The following is a description of a gene set: Enables the transfer of an ion from one side of a membrane to the other. Human Gene Set: GOMF_MONOATOMIC_ION_TRANSMEMBRANE_TRANSPORTER_ACTIVITY species: Homo sapiens, and this is the list of marker genes: KCNK17 (NCBI Gene Id 90081), SLC30A10, KCNJ18, TRPC3, ATP5ME, SLC18A3, SLC30A9, MT-ND6, TRPM7, CACNA1G, SFXN2, CACNB2, KCNQ1, TPCN1, MT-CO1, CATSPER2, PCSK9, HCN1, MT-CYB, KCNG3, NMUR2, GABRG2, ATP1B1, SLC39A9, SCN2B, SLC39A5, DRD4, TSPOAP1, SLC38A3, ATP2B4, CACNA2D2, SLC2A9, NIPAL4, SLC18A1, SLC45A2, CACNA1H, SLC1A3, SLC39A4 (NCBI Gene Id 55630), KCNQ4, CHRNA2, ATP6V0A1, KCNK13, CALHM5, HTR3B, PIEZO2, TMPRSS3, STOM, SLC26A4, HCN2, GLRA3, CLCN1, TMC5, SLC26A7, CABP4, SLC9C1, SLC6A18, CRISP1, SLC39A10, CLDN4, NDUFS1, SLC23A1, ANO6, CACNA1A, SLC5A7, SLC28A1 (NCBI Gene Id 9154), KCNK3, KCNG4, TCIRG1 (NCBI Gene Id 8845), SLC34A2, ASIC5, ATP6V0C, FLNA, STIMATE, SLC24A3, SGK3, GPD1L, NDUFS3, ORAI2 (NCBI Gene Id 84917), NDUFS2, CLCN7, ASIC2, ATP6V1B1, GPR89A, KCNH5, AGT, KCNJ12, SLC17A8 (NCBI Gene Id 64944), PKD1L1, GABRE, GJD3, PKD2, SLC9A2, GABRR1, OCA2, CYC1, PKDREJ, GRIK4, ANK3, KCNH2, FXYD5, SLC9A6, NIPAL2 (NIPA like domain containing 2), CHRNA4, SLC11A1, NDUFS8, TMCO3 (transmembrane and coiled-coil domains 3), SLC38A1, TRPM2, KCNK16, CACNA1C, UQCR10, TRPC6, SCN9A, SLC38A7, ATP13A2, RSC1A1, ATP2C1, SLC25A4, KCNK6, KCNA10, NDUFB10, ANO10, GRIN1, CACNA1F, NEDD4, NDUFS6, ATP6V1G1, ANK2, NDUFV3, AQP1, GRIK1, TRPC7, SLC26A11, NDUFC2, TRPV1, SLC28A3, ATP6V1E2, GABRA4, SLC30A8, SLC46A1, SLC5A9, SLC17A7, CNGB1, SLC31A1, SLC26A5, SLC39A6 (solute carrier family 39 member 6), VTI1B, MT-CO3, DPP6, ANKRD36C, LAMP2, RYR1, HAMP, MT-ATP6, STX8, TTYH2, SLC12A2, TMC4, NIPAL1, NDUFS5, CACNG1, REM1, SLC5A4, SLC16A1, SEC61A1, SLC10A2 (NCBI Gene Id 6555), ENSA, NDUFB2, SCN10A, SLC9A8, VAMP8, SLC10A1, APOL1, NHERF1, SLC8A2, ANO3, CACNA2D1 (NCBI Gene Id 781), STIM1, SLC25A14, SLC1A2, NDUFB4, SLC39A7, LAMP1, UCP1, CACNA1S, CHRNA1, KCNV1, TMEM109, COX5B, KCNMB4 (NCBI Gene Id 27345), GABRQ, NDUFB6, MT-CO2, CLIC4, TMEM37, COX4I1, PDE4D, ATP4A, CLCA1, PACSIN3, SLC26A3, SLC13A3, KCNH1, SLC12A7, GABRA6, KCNJ16, UQCRH, SLC18B1, SLC25A22, CALHM4, TTYH1, CLIC2, CHRFAM7A, FKBP1A, CACNG4, GRIN2D, KCNJ8, COX6B1, SCN2A, SLC17A4, SLC30A6, BEST4, ATP5PF, SLC39A3, SLC8B1, ANO2, SLC46A3, SLC5A12, SLC15A1, ZACN, SCN3A, TMC6, ATP13A3, HCN4, ATP2A2, PHPT1, NDUFA7, SLC10A4, SLC25A28, KCNH8, P2RX7, SLC5A11, P2RX6, GRIK5, SLC4A8, SLC5A2, SLC25A12, ASIC1, SLC13A1, KCNMA1, NNT, CUL5, CNGA4, CABP5 (calcium binding protein 5), TMEM120A, KCNK9, SLC30A2, PSEN1, GABRA5, NOX5, FKBP1B, TMC2, SLC15A2, ROMO1, MFSD2A, NDUFA1, KCNN2, KCND2, TUSC3, BEST3, SLC1A6, ATP6V1F, KCNG2, ITPR1, KCNN4, SLC47A2, P2RX3, SLC10A3, ANO1, CATSPER3, SLC9A7, ATP4B, CAV3, TRPM6, GABRR3, ATP6V0E1, ASIC3, CACNB1, COMMD1, KCNJ3, NDUFB1, HCN3, GLRA1, SLC36A1, PKD1, SLC4A11, SGK2 (NCBI Gene Id 51178), REM2, SLC17A3, SLC5A10, GRID2, STX7, COX7A1, ATP8A1, KCNE5, TMC8, KCNAB1, CCT8L2 (chaperonin containing TCP1 subunit 8 like 2), ATP5F1A, GJA1, NDUFB9, TMEM38B, NDUFA12, PKD2L1, GJC1, ATP5MF, ADRB2, MT-ND4, ATP11B, NDUFC1, NDUFA6, TMCO1, KCNK12 (potassium two pore domain channel subfamily K member 12), SLC39A13, SLC39A12, SLC30A5, KCNC3, SLC17A2, SLC6A20, VDAC3, ATP6V0E2, SCN11A, ATP1A3, SLC6A14, KCNMB3, GPR89B, SLC39A11, CTNS, SCN1A, CACNG3, GRIN3B, ORAI1 (ORAI calcium release-activated calcium modulator 1), LRRC55, CLCN2, SLC39A2, TRPM1, CLCN3, OTOP2, ANO5, CLCN5, SCN3B, SLC28A2, SLC25A3, SLC12A9, MT-ND3, KCNB2, KCNQ2, PIEZO1, ATP5MC3, TPTE, AMIGO1, SLC26A1, ATP6V1G2, PTPN3, AKT1, SCN4B, CNGA1, KCNK18, SLC22A1, TRPC4AP, LETM1, GRIA1, FXYD6P3, KCNJ11, TMEM94, SLC13A4, CHRNB3, SLC11A2, CALM3, TMEM165, CNNM4, SLC29A1, CACNG8, FGF11, MAGT1, KCNN3, P2RX2, CACNA1I, KCNH6, SLC19A1, SLC9A9, NDUFB7, KCNA1, KCNU1, KCNJ2 (potassium inwardly rectifying channel subfamily J member 2), BSND, NCS1, STIM2, SLC6A8, SLC12A5, FXYD7, KCND3, CLIC1, GLRX, SLC13A2, SLC26A2, SLC45A4, ORAI3, SCN5A, CLCNKA, TRPV5, UQCRFS1, SLC24A1, PANX3, KCNJ9 (NCBI Gene Id 7820), SLC2A13 (NCBI Gene Id 114134), GHITM, KCNF1, SFXN5, CLCN4, ATP7A, HTR3D, CACNG2, GABRA2, NDUFA8, RYR3, RANGRF, NRXN2, CALM1, DRD2 (NCBI Gene Id 91906), CHRNA10, KCNC1, SLC6A7, SLC2A10, FGF12, CACNB4, SLC30A4, KCNAB3, CALHM1, SLC17A5, SLC8A3, TMEM168, CHRNA3, SLC26A8, CHRNB1, NDUFV2, GEM, KCNE3, ATP12A, KCNA5, RASA3, SLC17A6, ATP13A1, AQP6, SCN4A, KCNH4, LRRC8C, CACNG7, ABCC8, S100A6, KCNH7, MTCO2P12, DLG1, MCOLN1, SGK1, NDUFB5, ATP2B2, KCNQ5, KCNK15, GABRB3, CHRNA6, UQCRFS1P1, SLC26A9, COX8A, CACHD1, SLC9B2 (NCBI Gene Id 133308), GRIN2A, GABRA3, TMEM120B, UCP3, CALHM6, SLC45A3, UCP2, ATP2C2, LRRC26, BEST2, TMC1, MT-ATP8, KCNC2 (potassium voltage-gated channel subfamily C member 2), PKD1L2, GRM2, PACC1, KCNIP4, KCNA3, SFXN3, NDUFS4, SNTA1, OPRM1, SLC9A1, GABRB2, CATSPER1, SLC25A13, ASIC4, FXYD1, TRPV4, SLC20A2, SLC24A2, CHRNA5, NPY2R, GABRP, SLC30A1, SLC32A1 (solute carrier family 32 member 1), VDAC1, CALM2, CHRNA9, CALHM2, SNAP25, ATP6V1C1, ATP6V1H, UQCRC1, HVCN1, CACNA1B, CABP1, ATP6V1A, GPLD1, KCNG1 (potassium voltage-gated channel modifier subfamily G member 1), RRAD, GRINA, CACNA1E, SFXN1, MT-ND4L, ATP6V1G3, LYNX1, ATP5F1EP2, CLCA4, KCNJ10, SLC5A6, MFSD8, RYR2, GRIK3, WWP2, SLC5A5, FGF13, FHL1, KCNE1, SLC12A8, TNNI3, SLC30A3, ATP6V0D2, SCN7A, KCNJ14, CHRNB2, CNNM2, NEDD4L, CNGA3, GRIN2B, GABRD, CLIC5, SLC18A2, NDUFA9, ATP6V1B2 (ATPase H+ transporting V1 subunit B2), GABRR2, FXYD2, CACNA2D4, LRRC52, CLCA2, C8orf44-SGK3, SLC4A4, SLC17A1, SLC47A1, SLC25A18, CACNA2D3, YWHAH, KCNMB1, KCNAB2, TPCN2, P2RX4, KCNMB2, ATP5MGL, LRRC38, SRI, KCNIP2, KCNE2, ABCC9, SLC15A3, PLP2, TPTE2, GRIK2, COX7A2L, KCNT1, SLC24A4, ATP5PD, SFXN4, TRPA1, CLIC3, ATP5MC2 (ATP synthase membrane subunit c locus 2), SLC6A3, SLC39A14, KCNJ1, MT-ND1, TRPM5, ATP2A3, ZDHHC13, SLC15A4, STK39 (NCBI Gene Id 27347), CACNG5, LASP1, SLC12A1, ATP6V0B, ATP6V1E1, TRPV3, ATP13A4, SHOC2, GABRG1, SLC6A12, HTR3E, CNGB3, SUMO1, ATP5F1D, KCNN1 (potassium calcium-activated channel subfamily N member 1), MT-ND5, TRPC1, ITPR3, VDAC2, SLC6A1, NIPA2, SLC6A15, RACK1, SLC1A4, SLC12A4, SLC39A8, CLCC1, HTR3C, ATP2B1, KCNT2, CNGA2, ATP5F1B, MCOLN3, SLC4A1, NPY, SLC6A4, SLC4A10, MMGT1, SLC16A3, SLC41A2, SLC36A3, HPCAL4, TMEM175, FGF14, ANO9, ATP5F1E, GRM3, ARPP19, FXYD3, KCNK1, GABRA1, SLC26A6, ANXA6 (NCBI Gene Id 309), ANO7, STING1, TMEM150C (transmembrane protein 150C), NDUFS7, KCNB1, GRIA3, SLC6A6, HTR3A, CAMK2D, SLC4A7, SLC45A1, SLC5A3, BNIP1 (NCBI Gene Id 662), GRIA2, SLC5A8, CHRNB4, ATP6V0A2, KCNIP3, TRPV6 (NCBI Gene Id 55503), TMC3, LRRC8D, SLC24A5, KCNJ6, LRRC8A, YWHAE, TMBIM1, NDUFA2, NALCN, CLDN17, LRRC8B, ATP5PB, TMBIM4, SLC38A5, KCNK10, KCNS2, NDUFA3, KCNJ5, SLC13A5, PKP2, CHRNG, TMEM87A, UNC80, GLRA2, NIPA1, SLC1A7 (solute carrier family 1 member 7), SCNN1B, ATP6V0A4, PDE4B, SLC41A1, KCNK2, CALHM3, SLC6A11, CACNB3, KCNK7, TRPM3 (NCBI Gene Id 80036), ATP5F1C, SHROOM2, MRS2, CFTR, SLC31A2, ATP2A1, KCNIP1, SCNN1G (sodium channel epithelial 1 subunit gamma), CHRND, ATP1A1, SLC12A6, GRIN3A, NDUFA10, CABP2, SCLT1, SLC36A2, KCNH3, CACNG6, GLRB, KCNE4, SLC9B1, DPP10, GRIA4, ATP6V1C2, P2RX5, CLIC6, SLC12A3, KCNK5, CLCN6, FAIM2, PKD2L2, SLC4A9, SLC39A1, TMC7, STX1A (syntaxin 1A), GPM6A, SLC9A5, KCNJ15, SLC8A1, OTOP1, SLC4A5, KCNQ3, WNK4, CHRNE, MCU, SLC6A13 (solute carrier family 6 member 13), CLCNKB, AKAP9, SLC34A1, NOS1, NALF1, SLC6A9, SLC23A2, CHP1 (calcineurin like EF-hand protein 1), KCNV2, ANO4, SLC6A5, KCNJ4, SLC20A1, NRXN1, KCNA6, TMEM63B, SLC26A10P, TMEM38A, AMBP, ATP6V0D1, PKD1L3, MT-ND2, CAV1, GRID1, ATP7B, CCDC51, CLDN16, SLC30A7, SLC25A37, SLC38A2, CHRNA7, KCNS1, PRKG1, KCNK4, SLC25A5, ATP2B3, TRPC5, KCNA7, NALF2, OXSR1 (NCBI Gene Id 9943), ATP5MC1, LRRC8E, SLC4A2, ITPR2, SCNN1D, MCOLN2, FXYD4, KCNS3, MICU2, SURF1, SLC10A6, CYBB, TMEM63C, TRPV2, SLC1A1, MICU3, SLC25A27, KCND1, SLC9C2, NDUFB8, SLC34A3, SLC29A4, ANO8, ATP6V1D, P2RX1, SLC5A1, SCNN1A, SLC9A3, ITGAV, SCN1B, KCNA4, NIPAL3, SLC41A3, NDUFA5, SLC9A4, TSPAN13, GABRB1, NDUFV1 (NADH:ubiquinone oxidoreductase core subunit V1), TRPC4, DMAC2L, SLC38A4, MICU1, TMBIM6, ATP13A5, NDUFA4, COX5A, ATP5MG, SCN8A, CACNA1D, TRPM8, KCNA2, FXYD6, ATP1A2 (NCBI Gene Id 93186), PRKCB, KCNC4, RASA1, SLC6A2, PANX1, NDUFB3, BEST1, SLC40A1 (solute carrier family 40 member 1), GABRG3, GRIN2C, SLC10A5, TTYH3, NHERF4, COX7B, MCUB, SLC4A3, TMEM63A, ATP5PO, GSTM2, KCNJ13, CATSPER4, DCD, OTOP3, TRPM4, ATP1A4